Given this list of marker genes ATG14, SEC31A, BCAP31, HLA-A, HSPA5, HLA-F, SAR1B, SEC13, CALR, HLA-C, SEC24D (SEC24 homolog D, COPII coat complex component), TAP1, SEC24C, ERAP2 (endoplasmic reticulum aminopeptidase 2), TAPBP, HLA-E, TAP2, PDIA3, PIK3C3, SEC23A, HLA-B, HLA-G, ERAP1, B2M, PIK3R4, SEC24A, SEC24B (SEC24 homolog B, COPII coat complex component), BECN1, CANX, here is a description of the gene set: species: Homo sapiens Antigen Presentation: Folding, assembly and peptide loading of class I MHC Human Gene Set: REACTOME_ANTIGEN_PRESENTATION_FOLDING_ASSEMBLY_AND_PEPTIDE_LOADING_OF_CLASS_I_MHC